The following is a description of a gene set: species: Mus musculus Genes predicted to be targets of miRBase v22 microRNA mmu_miR_6361 in miRDB v6.0 with MirTarget v4 prediction scores > 80 (high confidence targets). Mouse Gene Set: MIR_6361 from publication Chen Y, Wang X (PMID 31504780), and this is the list of marker genes: Samd4b, Kbtbd13 (NCBI Gene Id 74492), Pigm, Dhx33, Blzf1, Nova2, Prss44 (NCBI Gene Id 73336), Zfp820, Mboat1, Gorab, Crebl2, Bhlhe22, Ark2c, Klk10, Sting1, Kctd21, Gal3st2c, Scml2, Dmtn, Mydgf, Otud5, Med8, Spon1, Slc25a25, Brd8 (bromodomain containing 8), 3110082J24Rik (RIKEN cDNA 3110082J24 gene), Dlgap4, Mecp2, Snn (stannin), Zcchc14, Rap1b, Luc7l, Zfp811, B3gnt5, Lmtk2, Lsamp, Entpd6, Tada2b, Grik3 (NCBI Gene Id 329940), Smagp, Insig1, Zfp654, Ntsr1, Kif3b, Fyb2, Nav2, Anks1, Atp13a2, Zfp68, Rc3h2 (NCBI Gene Id 77277), Gal3st3, Nlk, Rbm3, Fst, Pkdcc, Foxred2, Cyb561d1, Sphkap, Zfp600, Rps15a, Dock3, Klrb1a, Dagla, Hspb7, Gfer (NCBI Gene Id 11692), Stradb, Ebf2, 2510009E07Rik (NCBI Gene Id 72190, RIKEN cDNA 2510009E07 gene), Sema4a, Nfxl1, Polr1e, Vav2, Plod2, Lmbr1l, Pml, Xpo7, Wnt8b, Zxdc, Rap1a, Appl2, B4gat1, Plcl2, Tceanc2, Tpmt, Amotl2, Zfp975, Ppp1r16b, Dusp8, Oxtr, Add2, Tmem70, Gfpt1, Kcnb1, G6pdx, Zfp942, Zbtb37, Rasal1, Mia3, Rmi1, Btaf1, Iffo2, Dgkk, Rapgef2, Kcnk2, Depdc5, Gbx2, Tmem267, Aldh5a1 (aldhehyde dehydrogenase family 5, subfamily A1), Top1, Fam210b, Dusp16, Map6d1, Gnao1, Gpr151, Trpm1, Abhd13, Camk2b, Sdf2, Taok1, Klf6, Matr3, Rab8a, Ago3, Ranbp10, Gm11545, Dnajb12, Agps, Diaph1, Nlrp6, Midn, Snap91, Rap2c, Rnf41, Sstr1, Zfp981, Nphp1, 2810459M11Rik, Tcf7, Mix23, C1qtnf1, Kcnip1, Snhg11, Lrsam1, Bcl2l11, Tmem245, Sncaip, Nemp1, Mau2, Als2, Lhpp, Laptm4b, Mxi1, Polr3d, Prdm1, Il1r1, Kptn, Slc25a44, Cdkn1b (cyclin dependent kinase inhibitor 1B), Spast, Ube2k, Tmem164, Ptger4, Zfp947, Tor2a, Hnf1b, Slc16a2, Mapk14, Trp53bp1, Cited4, Klhl1, Crat, Cnot6 (NCBI Gene Id 216722), Bco1 (beta-carotene oxygenase 1), Nefm, Ipcef1, Grip1, Ptprf, Ndst1, Cmtm4, Atad2b, Fgf11, Med13, Tmem161b, Avl9, Dyrk2, Vstm4, Stx5a, Pde1a, Calcr, Amz1, Nup210, Rala, Pskh1, Ncl, Neurod1, Mrc2, Apob (NCBI Gene Id 238055), N4bp1, Zfp980, Fsd1l, Kbtbd6, Tfcp2l1, Ugcg, Zfp697, Pla2g4e, Mboat7, Tspan14, Dlc1, Magi1, Ccdc25, Rasa1, Rex2, Rnf2, Ttc17, Calhm4, Zfp446, Klf8, Per1, Trim66, Dmrtb1, Abcb9, 9930012K11Rik, Chd5, Tmed8, Arid5a, Klhdc9, Igfbp4, Sart1, Stc2, Reep1, Chmp1b2, Skida1, Cers3, Nadk2, Sema4b, Cdh7, Tmem121b, Sesn1, Gad1, Zswim7 (NCBI Gene Id 69747), Vgll3, Pgap4, Sptlc2, Mrpl45, Ago4, Rubcn, Agpat1, Mbd6, Pdgfra, Apba1, Clcn3, Cdk16, Fam78b, Nrp2, Zxdb, Per2, Tbc1d24, Rnf138, H2ax